The following is a description of a gene set: Any process that modulates the frequency, rate, or extent of leukocyte chemotaxis. studied in species Homo sapiens Human Gene Set: GOBP_REGULATION_OF_LEUKOCYTE_CHEMOTAXIS, and this is the list of marker genes: STK39, VEGFB, RIPOR2 (RHO family interacting cell polarization regulator 2), TNFSF18, NBL1, CXCL8, CXCL12, DDT, KLRK1, VEGFD, NEDD9, IL6R, CALR, CXCL13, PLA2G7, CSF1R, DEFB124, MOSPD2, CREB3, WNK1, CCR2, THBS1, RIN3, BST1, NCKAP1L, RAC1, GPSM3, C5AR2, RAC2, CCL7, NINJ1, CCR6, SLIT2, S100A7, SPI1, LBP, F2RL1, RARRES2, CSF1, VEGFA, SLC8B1, CCL4, ADAM17, C3AR1, PGF, IL23A, C1QBP, SLAMF8, PTN, EDN2, MICOS10-NBL1, GAS6, PTK2B, TIRAP, XCL1, SWAP70, DPP4, CCL21, CX3CR1, CCL3, CXCL10, TNFSF14, OXSR1 (oxidative stress responsive kinase 1), LGMN, LGALS9, MMP28, GPR18, CCL19, HMGB1, AIF1, CCR7, MCU, EDN3, EDN1, CCL2, CCR1, ANO6, APP, S100A14, AKIRIN1, MDK, CCL1, DEFB131A, CCN3, CD74, SERPINE1, FPR2, TMEM102, MPP1, LYN, CYP19A1 (NCBI Gene Id 1588), CXCL17, TRPV4, ZNF580, DAPK2 (NCBI Gene Id 23604), MIR223, MIF, ADAM10, IL12A, SLAMF1, MTUS1, MAPK1, KLRC4-KLRK1, CMKLR1, IL6, C5, DUSP1, JAM3, PERP, F7, MAPK3, DNM1L, PTK2, WNT5A, MSTN, PTPRJ, VEGFC, CCL5, C5AR1, TNFAIP6, IL34, GREM1, THBS4, PADI2, STAP1, CAMK1D